The following is a description of a gene set: from publication Cui A, Huang T, Li S, Ma A, Pérez JL, Sander C, Keskin DB, Wu CJ, Fraenkel E, Hacohen N (PMID 38057668) Cytokines mediate cell-cell communication in the immune system and represent important therapeutic targets. A myriad of studies have highlighted their central role in immune function, yet we lack a global view of the cellular responses of each immune cell type to each cytokine. To address this gap, the authors created the Immune Dictionary, a compendium of single-cell transcriptomic profiles of more than 17 immune cell types in response to each of 86 cytokines (>1,400 cytokine-cell type combinations) in mouse lymph nodes in vivo. A cytokine-centric view of the dictionary revealed that most cytokines induce highly cell-type-specific responses. For example, the inflammatory cytokine interleukin-1β induces distinct gene programmes in almost every cell type. A cell-type-centric view of the dictionary identified more than 66 cytokine-driven cellular polarization states across immune cell types, including previously uncharacterized states such as an interleukin-18-induced polyfunctional natural killer cell state. species: Mus musculus Mouse Gene Set: CUI_CDC1_LTA1_B2_RESPONSE_UP Genes positively differentially expressed in cell type: cDC1 (conventional dendritic cell type 1) upon treatment with cytokine: LT-α1/β2 in mouse lymph nodes in vivo., and this is the list of marker genes: Txnrd1, Cdkn2d, Sap18, Ppm1b, Timm8a1, Nrros, Fzd7, Cd300a, Timd4